The following is a description of a gene set: Human Gene Set: WP_ULCERATIVE_COLITIS_SIGNALING studied in species Homo sapiens Ulcerative colitis signaling, and this is the list of marker genes: FOXP3, TGFB1, IL10, NFATC1, IL4, NFKB1, NOD2, TNF, IFNG, GATA3, IL13, IL2RG, HLA-DMA, MAF, IL4R, STAT6, TLR2, IL5